Given this list of marker genes GABRA1, SLC4A10, MRPS35, RERE, ZCCHC2, MYCT1, INTS3, MBTD1, AAK1, C3orf62, GSPT1, TMEM123, ZNF777 (NCBI Gene Id 27153), ELF5, DSE, PDLIM5, ARX, GLIPR1, YOD1, SPATS2, TSC22D1 (TSC22 domain family member 1), TRAK1, BIRC3, USP12, TSPAN3, BACE2, LY6K (lymphocyte antigen 6 family member K), PHF20L1, SLC23A2, MMUT, STK35, MARCHF6, TBC1D32, HEXIM1, PCNX1, SDF4, TENM4, DUSP4, ALDH5A1, SLC4A8, SCD, RAB2B, MSN, ZKSCAN8, P2RY10, TRIM35, UNC5C, NHERF1, SLC26A7, ANAPC7, TRIM33, DGKH, YWHAQ, ZNF480, MDM4, XBP1, ZNF280B, PFN2, HOXA5, ABHD13, SPTLC1, WFDC9, GPR88, ELOVL7, ADGRE3, FSIP1, AGO1, GABRA5, OPA1 (NCBI Gene Id 4976), JADE1, BCAT1, BRAF, ASB15, SRSF5, ADAT2, ENTHD1, WDR76, ZNF384, CARNMT1, TSFM, ZFP1, PDK3, WWC3, MDH1B, COL1A1, DDX4, BORCS5, BTG1, KCTD12, PAPLN (NCBI Gene Id 89932), MBNL3, PRSS16, LATS2, ZNF708, SHLD2, GDF9, MMGT1, CDC25B, TRPM3, MAP3K9, CDK11A (NCBI Gene Id 986), BCL11B, BNC2, PAX7, PPARGC1B, ZXDB, RANBP3L, TTC33, CADPS2, KRTAP26-1 (NCBI Gene Id 388818), TMEM107, CDKN1B, ANXA2R, SLC4A11, BARD1, SPCS2, KLF6 (NCBI Gene Id 8025), NID1, ATP1B2, GTF2H5, KL, ASB11, GOPC, PTBP1, WAPL, BOLA2-SMG1P6, CHAC2, PLK2, NAP1L1, KDM2B, TRAF6 (NCBI Gene Id 7189), ARHGAP5, FZD10, MYO5A, FOXO3, ADAM19, PCNP, TMF1, SPX, PALM2AKAP2, KMT2A, SEMA4D, DDA1, NHLH1, SLC9C1, TRIM66, ZBTB6, ABCG5, MTX2, SYNPO2, SUSD6, CCDC88A, SPRY3, WNK3 (WNK lysine deficient protein kinase 3), EHBP1, POLI, SSR3, PRRT4, CCSER2, SDE2, TRPC5, ARHGEF35, DOK6, ATP1B4, CUL4B, DBI, DIRC1, HMBOX1, TKTL2, ACSL6, CA13, YBX2, OSTM1, ACBD3, GPHN, PPFIA2, CDK11B, ARF3, SP1, GABRG2, PCP4, PROS1, IPO5 (NCBI Gene Id 3843), RPS20, ORC4, PHTF2, PAX5, MELTF, NMNAT2, PPM1E, SORCS3, ATP2C1, here is a description of the gene set: Genes predicted to be targets of miRBase v22 microRNA hsa-miR-6830-5p in miRDB v6.0 with MirTarget v4 prediction scores > 80 (high confidence targets). from publication Chen Y, Wang X (PMID 31504780) Human Gene Set: MIR6830_5P species: Homo sapiens